The following is a description of a gene set: GABA receptor signaling Human Gene Set: WP_GABA_RECEPTOR_SIGNALING species: Homo sapiens, and this is the list of marker genes: GAD2, GABBR1, GABRD, ALDH9A1, SLC6A11, ABAT, GABRQ, GABRA1, AP2A2, GABRG3, GPHN, GABRB3, GABRP (NCBI Gene Id 2568), AP2M1, AP2A1 (adaptor related protein complex 2 subunit alpha 1), GABRA4, GABRA2, GAD1, GABBR2, SLC6A1 (solute carrier family 6 member 1), GABRA6, GABRE, GABRG1, SLC32A1, GABRB2, AP2S1, GABRG2, GABRA5, GABRA3, AP2B1, GABRB1